The following is a description of a gene set: The covalent attachment of a fucosyl group to an acceptor molecule. species: Homo sapiens Human Gene Set: GOBP_FUCOSYLATION, and this is the list of marker genes: FUT11, B3GLCT, POFUT2 (NCBI Gene Id 23275), FUT4, FUOM, FUT9, POFUT1, FUT1, FUT8, FUT3, FUT2, FUT6, FUT7, SLC35C2, FUT10, FUT5